The following is a description of a gene set: Any process that activates or increases the frequency, rate or extent of neutrophil migration. species: Homo sapiens Human Gene Set: GOBP_POSITIVE_REGULATION_OF_NEUTROPHIL_MIGRATION, and this is the list of marker genes: MDK, XCL1, FUT7, TIRAP, EDN1, CCL21, CXCL8, CD99L2, LBP, RAC1, CCR7, MOSPD2, THBS4, ADAM8, DNM1L, IL23A, RIPOR2, DAPK2, RTN4 (NCBI Gene Id 57142), CD99, PERP, CAMK1D, RAC2, MCU, NCKAP1L, CCL19, XG, C3AR1, FUT4, IL1R1, CD74, C5AR1, C1QBP, SELENOK